Given this list of marker genes Polr1c, Polr2h, Polr3h, Polr2b, Polr1h, Polr2i, Polr1a, Tert, Polr2f, Polr2e, Polr3a, Polr3k, Crcp, Polr1d, Polr1b, Polr2j, Polr2l, Polr2a, Polrmt, Primpol, Polr2c, Polr2k, Prim1, Polr3b, here is a description of the gene set: Mouse Gene Set: GOMF_RNA_POLYMERASE_ACTIVITY Catalysis of the reaction: nucleoside triphosphate + RNA(n) = diphosphate + RNA(n+1); the synthesis of RNA from ribonucleotide triphosphates in the presence of a nucleic acid template. studied in species Mus musculus